The following is a description of a gene set: species: Homo sapiens Human Gene Set: GOBP_RESPIRATORY_BURST_INVOLVED_IN_DEFENSE_RESPONSE A phase of elevated metabolic activity, during which oxygen consumption increases made as part of a defense response; this leads to the production, by an NADH dependent system, of hydrogen peroxide (H2O2), superoxide anions and hydroxyl radicals., and this is the list of marker genes: PRDX2 (peroxiredoxin 2), LIPA, RPS19, DUSP10, SELENOK, MPO, NCF1, PIK3CG, TREM2, PIK3CD (NCBI Gene Id 5293), INS, HCK, LBP, GRN, S100A9, CYBC1, SLAMF8